Given this list of marker genes PHTF2, LOXL1, MEOX1, POLA1, DCPS, XRCC6, RACGAP1 (NCBI Gene Id 94651), CCNB2, SMC2, EHD1 (NCBI Gene Id 10938, EH domain containing 1), SLCO4A1, PTGER2, AGA, SMAD3, IL2RA, CREB3L2, CASP8, PPP1CB, RASGRP2, ST8SIA4, PPCDC, APOBEC3F, TK1, PA2G4, PRKCB, TRIP4, SLC27A2, MRE11, RFC4, THOC5, TPX2, PRC1, HINT1, NIT2, UBR7, HMGB2, EPS8L2, IL32, REXO2, TXNDC15, SMS, STK39, EIF2S2, GTPBP4, GPR171, TUBB, ARG2, TRAF3IP3, SP140, COL9A2, MCM6, ARHGEF6, GATA3, TKTL1, KLF2, SMC6, RNF44, ATAD2, RMI1, PDCD4, STAT4, KIF11, CALHM2, CASK, RAD50, PMCH, FKBP3, POGLUT2, SHMT2, HELLS, CARS1, JTB, DHFR, NCAPG, COL6A3, GFI1, GALT, CAPN2, RFC3, NUP107, USP14, UCP2, TMPO, CFLAR, PTBP3, RBPJ, CBFB, POLH, PSMB4, STN1 (STN1 subunit of CST complex), FUT8, EIF4E2, PIP5K1B, SLC39A14, TEX30, MELK, KAT2B, SLAMF1, RBBP8, SLC43A1, HCLS1, TRADD, OPTN, BUB1B, TYMS, SLC25A12, CCNB1 (cyclin B1), RAP1GAP2, MCM2, SP110 (NCBI Gene Id 3436), ARAP2, BARD1, P2RX5, LANCL1, MLEC, ZNF33B, POP7, NOP56, ARHGAP19, MTHFD1, MANEA, RBKS, GPALPP1, P4HA2, NDC80, KIF18A, DIPK1A, CHFR, TMEM43, NME7, CD79B, AGPAT5, HPGDS, PCBP1, NUSAP1, BATF, SOCS2, FANCL, PPAT (phosphoribosyl pyrophosphate amidotransferase), NUP50, LASP1, TJP2, CSTF2, MAPK11 (mitogen-activated protein kinase 11), AVEN, MTMR1, KNTC1, CENPE, SPATS2L, CD38, BCL2, POLD3, CLIC1, IQGAP1, PCLAF, TAF5, MICAL2, CCR4, TACC1, RBM38, CCR2, SLC1A4, TAF2, SMC4, MARCHF3, PIEZO1, CSTF3, IL18R1 (interleukin 18 receptor 1), FNBP1 (NCBI Gene Id 23048), RFC5, NIBAN1, CUL3, TOPBP1, UBE2N, P2RY10, LTA, LBHD1, EPAS1, MLH1, BLM, SEC24C, UTP14A, GCH1, HDAC1, APOBEC3B, CRELD2, DLGAP5, KIF22, DDX46, KIF18B, BIRC3, CD226 (NCBI Gene Id 10666), TRAF1, KIF2C, HLA-A, ASPM, TAOK3, ESPL1 (extra spindle pole bodies like 1, separase), IFI16, here is a description of the gene set: from publication Prots I, Skapenko A, Lipsky PE, Schulze-Koops H (PMID 21347372) CD25+ regulatory T cells develop in the thymus (nTregs), but may also be generated in the periphery upon stimulation of naive CD4 T cells under appropriate conditions (iTregs). The mechanisms that regulate the generation of peripheral iTregs are largely unknown. We used microarrays to gain insights into the molecular program of extrathymic Treg development. Genes up-regulated in comparison of CD25+ regulatory T cell (Treg) treated with IL4 at day 10 versus CD25- T cells treated with IL4 at 10 h. Human Gene Set: GSE24634_TREG_VS_TCONV_POST_DAY10_IL4_CONVERSION_UP studied in species Homo sapiens